Given this list of marker genes Slc4a1, Rbfox2, Nmrk2 (NCBI Gene Id 69564), Camk1g, Gabrb2, Vcan, Csf1, Ralgapa1, Tnfrsf19, Pigk, Tmem255a, Fmo2, Dock2, Il1rap, Mmgt1, Megf10, Trpm8, Kcnrg (NCBI Gene Id 328424), Rp2, Grhl2, Cphx1, Arhgap25, Trim60, Hnrnph3, Acat1, Nsd1, Olfm1, Ppm1f, Cdk5rap1, Lin54, Arhgef37, Cacna2d3, Csrp1, Atcay, Adam12, Col27a1, B3galt5, Fgf9, Sufu, Plxna4, Foxg1, Ndufs2, Snx2, Ppp1r8, Mmrn1, Spsb4, Tnn, Dlg3, Fam149b, Stk4, Cxadr, Pcsk5, Dlx6 (distal-less homeobox 6), Asb4, Sipa1, Cmklr1, Zfp870, Zfp616, Pgrmc2, Zbtb18, Zfp874b, Slc23a1, Pde4a, Pheta1, Clp1, Ablim1, Stxbp4, Man1c1 (mannosidase, alpha, class 1C, member 1), Taf7l, Tmem8b, Marchf3 (NCBI Gene Id 70723), Tanc2, Zfp931, Has2 (hyaluronan synthase 2), Tmem170b (transmembrane protein 170B), Bmp7, Shox2, Ppm1a, Mbd6, Cln8, Ctnna1, Nlrp4g, Asb1, Vps25, Dhfr, here is a description of the gene set: from publication Chen Y, Wang X (PMID 31504780) Genes predicted to be targets of miRBase v22 microRNA mmu_miR_7037_3p in miRDB v6.0 with MirTarget v4 prediction scores > 80 (high confidence targets). Mouse Gene Set: MIR_7037_3P species: Mus musculus